The following is a description of a gene set: studied in species Homo sapiens Genes predicted to be targets of miRBase v22 microRNA hsa-miR-302e in miRDB v6.0 with MirTarget v4 prediction scores > 80 (high confidence targets). Human Gene Set: MIR302E from publication Chen Y, Wang X (PMID 31504780), and this is the list of marker genes: CLIP4, AGO1, COG5, EZHIP, SUZ12, RFX3, UHMK1, CHN2, KIF3B, NUFIP2, ASB13, TNRC6C, CYB5D2, MTCP1, TXNIP, UNC80, ZFX, PHACTR4, GPC6, DYNC1LI2, TET3, PSD3, NHLRC2, HAUS8, ZNF2, SLC45A2, SAMD12, MYLK, AHR, CUX2, ATAD2, ITGB4, SNX5, LMO3, CCSAP, ARHGAP30, HIPK3, TANC1, NFIA, CUX1, CNOT6 (CCR4-NOT transcription complex subunit 6), VLDLR, DCUN1D4, ST3GAL1, LATS2, KBTBD8 (NCBI Gene Id 84541), NCOA7, DCAF6, RSBN1L, RUBCN, TRERF1, ELAVL2, PHF12 (PHD finger protein 12), SYTL4, PKD2, RAB11A, GDF11, FRMD4A, ARMC8, AMER2, UBE2J1, HS2ST1, RFLNA, RNF216, ZNF800, CAPRIN2, RUNX2, PLEKHS1 (pleckstrin homology domain containing S1), ROCK2, CREB5, CMTR2, PIGA, HDAC4, ZNF385A, INHBB, KAT2B, IKZF2, TMEM86A (transmembrane protein 86A), KREMEN1, FBXO41, BARX2 (BARX homeobox 2), ANKRD13C, TWF1, DUSP2, ZNF532, RSF1, NFYA, DNAI7 (dynein axonemal intermediate chain 7), SYNC, SLC40A1, GPCPD1, PDE4D, ASXL3, RAB11FIP1, ARHGEF17, ZNRF3, ZNF362, VDR, RTN1, ATP6V0B, RAB5C, ITGB8, PBK, SNX8, RASSF2, FYCO1, GLCE, PAK2, CXCR4, TMEM64, ATF6B, DGKH, RORA (RAR related orphan receptor A), MAP3K2, ZNF260, TMEM123, DERL2, FBXL17, FGD5, CADM2, IFNLR1, MBD2, RASGEF1A, FCMR, APP, MAP3K14, UBE2B, C5orf24, RBBP9, FEM1C, MCL1 (MCL1 apoptosis regulator, BCL2 family member), TNKS2, BCL11A, TBC1D2, MTMR4, ZFYVE26, MAPK9, GK5, EXOC5, SLAIN1, OLFM3, TRAPPC14 (trafficking protein particle complex subunit 14), TAGAP, OSTM1, CYBB, SOWAHC, CRIM1, CDC23, SYDE2, OXR1, MBNL3, GALNT3, RIMKLA, NHLH2, HIP1, RB1CC1, FAM219B, NFIB, ZBTB5, ZC3H13, ZBTB7A, YTHDF3, REEP3, PHKA1, BCL6, QRSL1, SPRED1, ZFP1, TMEM62, PARP8, PKHD1, DENND5B, NTN4, H2AJ, ARID4B, MYT1L, LARP1B, ZBTB41, FZD6, MANEA, TET2, PRDM8, TMEM100, ANO6, MAGEH1, INO80D, SETD9, KLHL2, GOLGA1, UBE2Q2, DCUN1D1, WDR26, PRRG1, MIXL1, LEFTY1, TMUB2, LHX6, E2F2, MPC1, C9orf72, TARDBP, OR51E1, DCUN1D5 (defective in cullin neddylation 1 domain containing 5), ZNF776, A1CF, RASAL2, SERF1A (small EDRK-rich factor 1A), GPM6A, APOBEC4, HECTD2, SLC16A6, SKIDA1, NHSL3, ZBTB11, PRR16, LRP8, PAPPA, FGD4, FAT4, MFAP5, ANKRD45, TIMM17A, MXD3, LAMA3, CHURC1, TET1, FMR1, PPARA, TAOK1, MYCN, ARL4C, SCARA5 (scavenger receptor class A member 5), MARCHF5, DPYSL5, TMEM170B, TRIP11, IRF2, PDIK1L, NCOA3, PFKP, SLAIN2, ACTL6A, C2orf69, SLC15A2, ANKRD17, ZNF711, FNDC3A, HP1BP3, NPAS3, RGMB, CORO2B, PRDM16, MSL1, POLQ, PAF1, MIGA2, TIAM1, JAK1, ZNF827, LAMP5, KDM1B, MTF1, RABGAP1, EDNRB, MAN1A1, CDCA7, NAPEPLD, SLC33A1, GATAD2B, ARID5B, RPS6KA3, KRTAP1-3, EZH1, DPP8, GUCA1C (NCBI Gene Id 9626), BTG1, R3HDM1, CFL2, SLC43A2, YOD1, ZNF367, MFN2 (mitofusin 2), POU2F1, GLIS3, E2F5, RRAGD, RNF6, ZNF77, GUCY1A2, SERF1B, ISM2, MASP1, MICA, C2CD2, SSX2IP, TEX2, CELF2, RETREG3, ZMYND11, NOL7, PDE8A, TSEN34, GPR12, ZNF25, PLAGL2, SNTB2, PTPRD, RDX, CPEB1, GPR6, FSD1L (fibronectin type III and SPRY domain containing 1 like), ELK4, MIER3, KDM7A, SON, SPTLC2, RAB22A (RAB22A, member RAS oncogene family), ST7L, ZNFX1, UNKL, PPP6C, KPNA2, BCAP29, IRF2BP2, CXCL14, LRIT1, SDC1, MKNK2, DDHD1, CXCL1, CYP26B1, RELA, PIGM, RBL1, RYR2, MCC, GRPEL1, ARID4A, MIB1, ASXL2, SLC22A3, SAR1B, ALX4, SLC22A23, DMTF1, SRCIN1, ASF1A (anti-silencing function 1A histone chaperone), GNPDA2, TFAP4, SLC16A10, ZKSCAN1, ZNF652, PAK5, ARHGEF10, SUCO, TENM2, CROT, NR2C2, ANKRD52 (ankyrin repeat domain 52), ZBTB25 (zinc finger and BTB domain containing 25), PHF14, SH3TC2, TMTC2, SMARCC2, ASAP1, ZFPM1, ZCCHC24, SMNDC1, ADAT2, TMEM183A, TESK2, RGL1, SHCBP1, RAB11FIP5, NHLRC3, GPR158, PLAG1, PRDM4, FAM168B, CREBRF (NCBI Gene Id 153222), SPOP, ITPRIPL2, BLCAP, IGHMBP2, ESRP1, ABHD3, MRPL42, LEFTY2, CUL3, SHC4, TNFAIP1, TGFBR2, RELL1, CYBRD1, TOX, SYDE1, MLLT6, GUCY1A1, EPHA5, ZRANB1, TP53INP1, SLC24A2, FZD3, GPR161, ERCC4, NR4A2, CYP20A1, MED17, USP16, ZBTB33, ATXN1, EIF3M, TIPARP, LYST, SOX6, C6orf15, RALGDS, GSTM3, MTMR3, AVL9, SMIM14, JAZF1, ALDH1L2, DNAJC27, CCNJ, TAPT1, WDR37, TNRC18, RSBN1, PPM1L, NR4A3, MFAP3L, TBC1D8B, REST, FSTL5, MED12L, ERBB3, MYRF, SS18L1, SETBP1, MTUS1, TRIM36, SNRK, ATP2C1, KIF26B, VPS35, DCDC2, AAK1, LCOR, DRD1, USP46, HIF1AN, PTGDR, MARCHF11, TCAIM, PRR11, ASF1B, BNIP3L, HABP4, SEMA3C, ZNF75A, ACADVL, GRM5, TRPV6, SUV39H1, E2F7, LHX8, TSHZ3, RAD18, PTPN21, TRPS1, ADAM9, PIKFYVE, LRP2, HOOK3, KMT5B, USP24